Given this list of marker genes Atrx (NCBI Gene Id 67403), H2al2a, Hira, H1f5, Padi4, H1f8, Macroh2a1, Shprh, Baz1a, Brd2, Smarca2, Hp1bp3 (NCBI Gene Id 15441), H1f1, Kat6a, Atad2b, Naa60, H2bc1, Grwd1, Chrac1, Asf1b, Tspyl1 (testis-specific protein, Y-encoded-like 1), H1f4, Tspyl4, Nap1l5, Smyd3, H4c14, Sox9, H1f9, Mcm2, Tspyl2, Nap1l4, Anp32b, Daxx (Fas death domain-associated protein), Smarca4, Spty2d1, Sart3, H1f3, Chaf1b, Asf1a, Set, Chaf1a, H3f3c, Macroh2a2, Npm1, Smarca5, Nap1l1, H1f0, Ssrp1, Pole3, Kat6b, Nasp, Ubn1, Rsf1, Atad2, Tspyl5, Nap1l2, Dnajc9, H1f6, H1f2, Rbbp4, Nap1l3, Supt16, here is a description of the gene set: species: Mus musculus Mouse Gene Set: GOBP_NUCLEOSOME_ASSEMBLY The aggregation, arrangement and bonding together of a nucleosome, the beadlike structural units of eukaryotic chromatin composed of histones and DNA.